The following is a description of a gene set: Any process that results in a change in state or activity of a cell (in terms of movement, secretion, enzyme production, gene expression, etc.) as a result of a chemical stimulus indicating the organism is under stress. Mouse Gene Set: GOBP_CELLULAR_RESPONSE_TO_CHEMICAL_STRESS species: Mus musculus, and this is the list of marker genes: Pik3ca, Vkorc1l1, Trpa1 (transient receptor potential cation channel, subfamily A, member 1), Mb, Atf2, Src, Atg7, Wnk3, Ppef2, Ermp1, Sirt6, Ppia, Atp7a, Mmp3, Pink1, Abcd1, Etv5, Arnt, Slc25a23, Sod3, Xrcc6, Pck1, Pcna, Meak7, Mlst8, Nlrp3, Ang, Ripk1, Hsf1, Chuk, Prkaa2, Aifm1, Mgat3, Pjvk, Zfp277, Hk3, Sesn2, Cst3, Cyp1b1, Tet1, Foxa1, Prr5l, Foxo1, Cln3, Slc11a2, Mgst1, Oxsr1, Letm1, Chchd2-ps, Prkra, D1Pas1, Mapkap1, Tbc1d24, Atm, Selenos, Htra2, Serpinb6c, Wnk1, Cdkn2a, Nos3, Tldc2, Pex13, Mir7b, Dnaja1, Mir9-2, Slc12a6, Rcsd1, Slc8a1, Cdk1, Gdf15, Nlk, Pdgfd, Zc3h12a, Ect2, Pdgfrb, Sirt1, Zfp580, Pkd2, Lonp1, Aqp5, Rps3, Prdx2, Axl, Btk, Rnf146, Ppif, Mdm2, Pdgfra, Setx, Casp3, Smpd3, Mapk9 (NCBI Gene Id 26420), Stox1, Ddr2, Ncoa7, Fxn, Atp1a1, Mir29b-2, Trp53, Trpm2, Gjb2, Clcn2, Dapk1, Atf4, Serpinb6d, Stx2, Mapk1, Lcn2, Reg3b, Hif1a, Klf2, Ptprk, Il18rap, Adprs, Akt1, Coq7, Hspa8, Pyroxd1, Il6, Rack1, Ddit3, Pex5, Jun, Endog, Rhob, Fut8, Ngfr, Mylk (myosin, light polypeptide kinase), Becn1, Net1, Prkaa1, Atp2a2, Pex2, Gpx5, Mmp9, Ankzf1, Ern1, Pcgf2, Ninj1, Mpv17, Capn3, Lrrc8c (NCBI Gene Id 100604), Nme8, Hdac6, Wnt16, Map2k7 (mitogen-activated protein kinase kinase 7), Stk39, Hspb1, Rwdd1, Slc2a1 (NCBI Gene Id 20525), Abcc9, Epo, Nr4a2, Eif2s1, Agap3, Park7, Crygd, Aifm2, Fer, Cd36, Serpinb6b, Pycr1, Snca, Pdcd10, Capn1, Ambp, Prkd1, Scn2a, Brf2 (BRF2, RNA polymerase III transcription initiation factor 50kDa subunit), Arl6ip5, Aldh3b1, Romo1, Apex1, Dhfr, Mapk7, Fancd2 (Fanconi anemia, complementation group D2), Srxn1, Abl1, Nox1 (NADPH oxidase 1), Cbx8, Tmem161a, Stk26 (serine/threonine kinase 26), Prkcd, Mir99a, G6pdx, Cul3, G6pd2, Mir9-1, Txn1, Rbx1, Slc7a11, Chchd2, Ppargc1a, Mir100, Micu1, Penk, Sod1, Kdm6b, Slc25a24, Met, Parp1, Psap, Mapk13, Foxp1, Prdx5, Xrcc5, Mmp2, Scn7a, Oxr1, Pycard, Atp13a2, Crygf, Rptor, Gpr37l1, Sod2, Cat (NCBI Gene Id 269322), Chchd4, Cryge, Edn1, Relb, Map3k5, Serpinb6a, Msra, Trpv4, Egfr, Apoa4, Pex14, Ednra, Trex1, Tsc1, Scly, Bdkrb2 (NCBI Gene Id 12062), Bmp4, Mtor, Sin3a, Zfp36l1, Fos, Pml, Prdx3, Ep300, Naglu, Hgf, Fads2, Sirpa, Slc2a4, Txndc2, Vps13a, Nqo1, Lrrc8e, Mir137, Pycr2, Slc4a11, Rad52, Stk25, Cygb, Vrk2, Ddx3x, Mt3, Usp15, Ngb, Pnpt1, Efhd1, Dysf, Ezh2, Gch1, Stx4a, Ripk3, Mapk3, Akr1b1, Tspo, Dhrs2, Gsr, Xbp1, Ccs, Ucp1, Prdx1, Mapk8, Trpc6, Map1lc3a, Aif1, Kat2b, Nfe2l2, Ercc6l2, Mir204, Prkn, Pdk2, Abcb1a, Plec, Mir434, Tmigd1, Mir29c, Fabp1, Tifab, Stau2, Alox5, Klf4, Mir30b, Rbm11, Pnpla8, Prkg2, Slc1a1, Keap1, Top2b, Mir29b-1, Bmal1, Tnfaip3, Map2k4, Mir451a (microRNA 451a), Casp1, Gata5, Rela, Gpr37, Hdac2, Bnip3, Ddias, Ptgs2, Lrrk2, Bad, Stk24, Ppargc1b, Fbp1, Nfe2l1, Aqp1, Lrrc8d, Atg5, Plekha1, Fancc, Ogg1, Slc25a14, Anxa1, Pawr, Sphk1, Serpinb6e, Mpo, Cfl1, Trp53inp1, Oser1, Trpv3, Fyn, Ybx3, Fas, Pex12, Selenon, Stat6, Ggt1, Pex10, Cav1, Foxo3, Mir9-3, Pla2r1, Fbln5, Trap1, Sirt2